Given this list of marker genes Tkfc, Khk, Aldob, Glyctk, here is a description of the gene set: studied in species Mus musculus part of: Fructose metabolism Reactome Pathway: Fructose catabolism This event has been computationally inferred from an event that has been demonstrated in another species.<p>The inference is based on the homology mapping from PANTHER. Briefly, reactions for which all involved PhysicalEntities (in input, output and catalyst) have a mapped orthologue/paralogue (for complexes at least 75% of components must have a mapping) are inferred to the other species. electronically inferred by orthology from the curated human pathway